Given this list of marker genes RPS29, EIF1AX, RPSA, RPS19, RPS4X, EIF4E, EIF2S3, RPS5, RPS20, RPS10, RPS9, EIF5, EIF3G, EIF3F, EIF3I, RPS11, RPS14 (ribosomal protein S14), RPS3A, RPS12, EIF2S2, RPS7, RPS28, EIF3M, RPS4Y1, RPS25, EIF3C, RPS27A, RPS16, EIF3A, RPS6, EIF3J, EIF3K, RPS18, RPS21, EIF3L, RPS4Y2, EIF4A2, RPS15, EIF4A1, RPS27L, RPS15A (NCBI Gene Id 6210), EIF3D, EIF3B, RPS27, EIF4G1, RPS26, 18S rRNA, EIF4H, EIF4B, RPS23, RPS17, FAU, EIF3H, EIF3E, RPS3, RPS24, RPS8 (NCBI Gene Id 6202), EIF2S1, RPS13, RPS2, here is a description of the gene set: studied in species Homo sapiens Reactome Pathway: Ribosomal scanning and start codon recognition The 80S ribosome bound to the mRNA moves along the mRNA molecule from its initial site to the initiation codon and forms a 48S complex, in which the initiation codon is base paired to the anticodon of the Met-tRNAi. Proper recognition of the AUG initiation codon depends on base pairing with the anticodon of the Met-tRNAi and requires eIF1, eIF1A, eIF2 and eIF5. part of: Cap-dependent Translation Initiation